The following is a description of a gene set: Human Gene Set: GOBP_SPONTANEOUS_NEUROTRANSMITTER_SECRETION species: Homo sapiens Neurotransmitter secretion that occurs in the absence of the action of a secretagogue or a presynaptic action potential., and this is the list of marker genes: RPH3A, STX1B, PRKN, DOC2B, SYT1, DOC2A, RIMS2